Given this list of marker genes ZBTB16, DNMT3L, CDKN2D, GDNF, SYCP2, PIN1, CSF1, SLC19A2, UTP14A, RBP4 (retinol binding protein 4), STRA8, LIMK2, NANOS2, ADAMTS2, KIT, CYP19A1, ETV5, P2RX1, APAF1, BMP8B, GJA1, DDX4, DAZL, SOHLH2, BAX, here is a description of the gene set: Genes important for spermatogonia, based on mouse models with male reproductive defects. Human Gene Set: MATZUK_SPERMATOGONIA studied in species Mus musculus Reproduction is required for the survival of all mammalian species, and thousands of essential 'sex' genes are conserved through evolution. Basic research helps to define these genes and the mechanisms responsible for the development, function and regulation of the male and female reproductive systems. However, many infertile couples continue to be labeled with the diagnosis of idiopathic infertility or given descriptive diagnoses that do not provide a cause for their defect. For other individuals with a known etiology, effective cures are lacking, although their infertility is often bypassed with assisted reproductive technologies (ART), some accompanied by safety or ethical concerns. Certainly, progress in the field of reproduction has been realized in the twenty-first century with advances in the understanding of the regulation of fertility, with the production of over 400 mutant mouse models with a reproductive phenotype and with the promise of regenerative gonadal stem cells. Indeed, the past six years have witnessed a virtual explosion in the identification of gene mutations or polymorphisms that cause or are linked to human infertility. Translation of these findings to the clinic remains slow, however, as do new methods to diagnose and treat infertile couples. Additionally, new approaches to contraception remain elusive. Nevertheless, the basic and clinical advances in the understanding of the molecular controls of reproduction are impressive and will ultimately improve patient care. from publication Matzuk MM, Lamb DJ (PMID 18989307)